Given this list of marker genes JPH3, OPTN, C9orf72, CHCHD10, ATP7B, ZFYVE26, ATXN3, PRDX1, EIF4G1, RAB39B (RAB39B, member RAS oncogene family), PRICKLE1, CISD2, TMEM106B, PDGFB, MAPT, CHMP2B, NPC1, TAF15, MT-ND5, ITM2B, ERCC4, VPS35, PODXL, CSTB, PSAP, NR3C1, SDHD, LIG3, CYP27A1, PRNP, DNAJC13, MT-ND1, TWNK, RRM2B, NHLRC1, PRDM8, TREX1, ADA2, DNM1L, MT-TE, MT-TK, PPP2R2B, PANK2, FIG4, GBA2, ABCA7 (NCBI Gene Id 82843), VPS13C, VPS13A, NOTCH3, CHCHD2, ANG, CP, MT-TV, UBQLN2, HLA-DQB1, CSF1R, NEK1, HTRA2, SPTLC1, PINK1, OPA1, PSEN2, GLE1, LYST (NCBI Gene Id 1130), PLAU, LMNB1, SPAST, MT-TH, HTT, MT-CO3, APTX, DLAT, EPM2A, ADH1C, HNRNPA1, SCARB2, MT-TQ, MBTPS2, SAMD9L, PRKAR1B, C19orf12, ATRX, ABCB7, HEXA, MATR3, CLN6 (CLN6 transmembrane ER protein), ATP13A2, HNRNPA2B1, PSEN1, MT-TF, SORL1, SNCA, CCNF, LRRK2, MT-CO1, DCTN1 (dynactin subunit 1), NEFH, PDE10A, NR4A2, PDGFRB, STARD7, APP, ATP6V0A2, MT-CO2, SDHB, GPRC5B, CLN8 (NCBI Gene Id 619435), SLC13A5, NKX2-1, CST3, MT-ND6, AARS2, GBE1, MT-ATP8, FMR1, DNAJC6, UCHL1, TIA1, COL4A1, TBK1, FTL, NDP, CYLD, TYMP, WDR45, MT-TS2, SPG21, APOE, USP48, VCP, USP8, AARS1, MMACHC, MT-TW, GRN, ARSA, UNC13A, ANXA11, ERCC8, CLN3, DNMT1, PPARGC1A, AUH, CPT1C, SYNJ1, MPO, TOMM40, MT-CYB, FBXO7, MT-ND4, DGUOK, PNPLA6, NOS3, ALDH18A1, CFAP43, ATN1, SQSTM1, PON3, TUBA4A, HTRA1, TARDBP, SERPINI1, RNF216, SPG11, CFAP410, PRKN, MT-TT, KCTD7, TREM2, MT-ATP6, CERS1, DNAJC5, CDH23, SDHAF1, ATXN8OS, ASAH1, XPR1, PARK7, NOTCH2NLC, GBA1, ROGDI, TBP, GIGYF2, SNCB, TRPM7, ATP6V1E1, NPC2, WFS1, TIMM8A, POLG, GLT8D1, DAO, PON1, IRF6, GCDH, SNCAIP, CTSF, COQ7, CUBN, MT-TL1, TP53, BRAF (NCBI Gene Id 673), GALC, PFN1, ERBB4, MT-TC, ATXN10, FUS, GM2A, SDHA, ATXN2, TYROBP, NDUFA1, SOD1, ATP6V1A, TTR, TUBB4A, ABCD1, PRPH, MME, PON2, PLA2G6, VAPB, here is a description of the gene set: Human Gene Set: HP_DEMENTIA A loss of global cognitive ability of sufficient amount to interfere with normal social or occupational function. Dementia represents a loss of previously present cognitive abilities, generally in adults, and can affect memory, thinking, language, judgment, and behavior. Dementia species: Homo sapiens